The following is a description of a gene set: species: Homo sapiens Human Gene Set: REACTOME_HCMV_EARLY_EVENTS HCMV Early Events, and this is the list of marker genes: H2BC11, H2BC3, H2AC1, NCOR2, TUBA1B, TUBA3E, H2BC13, TUBB6, H2AC16, DYNC1I2, TUBA1C, H3C4, TUBA8, H2BC17, PML (NCBI Gene Id 5371), H3C6 (H3 clustered histone 6), POM121, H2AC8, NUP155, H4C6, NUP107, H2BC15, NUP188, HDAC3, H4C15, H2BC10, H2AC25, CBX1 (NCBI Gene Id 10951), NUP54, H2BC9, NUP98, POM121C, TUBA4B, H3C3, H3C14, NUP85, H2BC14, TBL1XR1, H3C10, TUBB2A, H3C13, DYNLL2, RAE1, H4C5, NUP210, NUP58, DYNC1LI2, ELK1, H2BC1, TUBB4A, NUP153, DYNC1H1, EZH2, TUBAL3, H3C11, H4C1, H2BC6, NFKB1, H2BC12, DYNLL1, NUP133, H3C12, H2AC20, H4C3, H3C1, SUZ12, TUBA3C, H4C11, GPS2, NUP42, H2BC8, NUP88, RANBP2, H4C14, H2AC12, RBBP4, H2BC5, RBBP7 (RB binding protein 7, chromatin remodeling factor), NDC1, H2AC4, H4C13, EED, TUBA1A, H3C15, TUBB4B, H2AC18, DYNC1LI1, H2BC7, H4C8, H2AC17, H2AC15, NUP50, TUBA4A, H4C4, DAXX, H2BC4, H2BC18, EGFR, H2AC19, H4C12, NUP43, CREB1, SEC13, H2AC21, TUBA3D, H3C2, TBL1X, H2BC26, H2AC11, H2AC7, H4C2 (H4 clustered histone 2), NCOR1, H4C16, NUP93, NUP205, TUBB8, H4C9, TUBB3, H2AC6, TUBB1, NUP160, DYNC1I1, TRIM28, H2BC21 (NCBI Gene Id 8349), H2AC14, TUBB2B, H2AC13, H3C7, TUBB8B, NUP35, TPR, NUP214, H3C8, NUP62, ITGB1, AAAS, SEH1L, NUP37